Given this list of marker genes NANOG, GBX2, ZIC2, SOX1, OTX2, PAX6, SOX2, ZNF521, POU3F1, POU5F1, ZEB2, here is a description of the gene set: species: Homo sapiens Human Gene Set: REACTOME_FORMATION_OF_THE_ANTERIOR_NEURAL_PLATE Formation of the anterior neural plate